Given this list of marker genes PRDX3, APOO, TNPO2, RFTN1, GABPB1, F3, STRBP, TBX21, RAB20 (RAB20, member RAS oncogene family), MAP3K13, SPIN4, ECHS1, CCT6A, TOR3A, CIRBP, CST7, TSPAN13, LAIR2, ANXA3 (NCBI Gene Id 306), TMCC3, MYCL, FBXO16, CCR7, ISG20, TNFAIP2, EYA3, ZNF641, CNNM4, C12orf75, CDKN1A, ELK1, IGFBP6, TMEM52B, MARCKSL1, CD274, EOLA2, SLC7A5, ASB2, EEF2 (NCBI Gene Id 408221), LYPD3, LRRC32, NDUFS8, ERICH1, JADE3, SIGLEC7, NXT1, HIC1 (HIC ZBTB transcriptional repressor 1), TSPAN33, RHBDF2, NFKBIE, OPLAH, NFKB2 (NCBI Gene Id 4791), CRLF2, PRDM1, EIF1B, IRF1, DNMT1, HSPBAP1, HERPUD1, RUBCN, TBC1D1, EHBP1L1, CYSLTR1, CSF2RA, IDO1, ANKRD33B, LRG1, ID3, LMNB1, HOXB6, ENSG00000284634, HBEGF, LIMCH1, HLA-DMB, TMEM138, INS, GPR132, FSCN1, GRAMD1A, IKBKE, ORAI2, BICDL1, CREBL2, TRIP10, KIAA1671, RGS1, SNHG16, DOK3, ENO3, CCL17 (NCBI Gene Id 6361), EIF4A2, ACVRL1, DOCK1, PGM2, CD1B, TNFRSF14, B3GALNT1 (beta-1,3-N-acetylgalactosaminyltransferase 1 (Globoside blood group)), PMAIP1, CYB561A3, SLC16A9, EOLA1, TMEM121B, ENOSF1, F8, IL18, GPR157 (G protein-coupled receptor 157), NOPCHAP1, HLA-DPB2, CPEB1, SEMA3E, PRKAR2B, NAP1L1, TLR3, RNF115, VOPP1, CFAP184, MAP3K14, KANSL3, TRIM6, CCL4, KCTD7, SLC22A18, TMEM268, RUNX3, BCL3, FGGY, IL1B, MRPS18A, DNAJB5, ABHD12, WARS1, BDH1, RPS27L, FLT3, MOB3A, GSDME (NCBI Gene Id 1687), SYNJ2, COL16A1, TIAM2, NSMCE1 (NCBI Gene Id 197370), TTLL4, TMIE, PITPNB, TPD52 (NCBI Gene Id 7163), CAMK1G, ACO2 (aconitase 2), FMNL3, LTV1, ZNF785, GALM, NFKB1, TRAFD1, PRXL2B, VPS35L, PHKB, POGLUT1, GRSF1, TAGAP, RAB29, FLNB, DTX2, BPI, FXYD6, GPR171, RASSF4, IL22RA2, SINHCAF, CD300LF, HOXB2, IMPDH2, STX18, PHLDA2, MTCL1, FAM117A, ALG2, IL15, DSP, NUB1, CYTIP, A1BG-AS1, GANC, CYBB, AMPD3, LONP1, FA2H (fatty acid 2-hydroxylase), PPA1, CD40, MYO1F, JARID2, BIRC3 (NCBI Gene Id 330), GATD3, NFKBID, GBP4, C6orf136, SOCS2, CFAP251, IDO2, here is a description of the gene set: T cell anergy is one of the mechanisms contributing to peripheral tolerance, particularly in the context of progressively growing tumors and in tolerogenic treatments promoting allograft acceptance. We recently reported that early growth response gene 2 (Egr2) is a critical transcription factor for the induction of anergy in vitro and in vivo, which was identified based on its ability to regulate the expression of inhibitory signaling molecules diacylglycerol kinase (DGK)-a and -z. We reasoned that other transcriptional targets of Egr2 might encode additional factors important for T cell anergy and immune regulation. Thus, we conducted two sets of genome-wide screens: gene expression profiling of wild type versus Egr2-deleted T cells treated under anergizing conditions, and a ChIP-Seq analysis to identify genes that bind Egr2 in anergic cells. Merging of these data sets revealed 49 targets that are directly regulated by Egr2. Among these are inhibitory signaling molecules previously reported to contribute to T cell anergy, but unexpectedly, also cell surface molecules and secreted factors, including lymphocyte-activation gene 3 (Lag3), Class-I-MHC-restricted T cell associated molecule (Crtam), Semaphorin 7A (Sema7A), and chemokine CCL1. These observations suggest that anergic T cells might not simply be functionally inert, and may have additional functional properties oriented towards other cellular components of the immune system. from publication Zheng Y, Zha Y, Spaapen RM, Mathew R, Barr K, Bendelac A, Gajewski TF (PMID 23548837) studied in species Homo sapiens Genes down-regulated in anergic CD4 Th1 cells: wildtype versus EGR2 knockout. Human Gene Set: GSE46242_CTRL_VS_EGR2_DELETED_ANERGIC_TH1_CD4_TCELL_DN